The following is a description of a gene set: Mouse Gene Set: GOCC_LIPID_DROPLET An intracellular non-membrane-bounded organelle comprising a matrix of coalesced lipids surrounded by a phospholipid monolayer. May include associated proteins. species: Mus musculus, and this is the list of marker genes: Or6c6b, Ckap4, Adig, Pnpla7, Irak1, Atg2b, Ces1h, Plin1, Sigmar1, Rab40c, Pnpla5, Hsd3b7, Ces1d, Ces1b (NCBI Gene Id 382044), BC031181, Pla2g4c, Cldn11, Gapdhrt2, Vcp, Set, Sccpdh, Rap1b, Akap1, Ces1f, Alox15, Ehd1, Fig4, Spast, Gbf1, Tmt1a2, Cav1, Cyb5r3 (cytochrome b5 reductase 3), Gimap7, Plin3, Gapdhrt, Chka, Or6c6c, Ces1a, Ldah, Zw10, Zfyve1 (zinc finger, FYVE domain containing 1), Faf2, Osbpl2, Aqp7, Cidea, Smpd1, Vps13c, Irgc, Dhrs3, Rab40b, Aifm2, Hsd17b13, Mgll, Abhd5, Plin2, Rab5c, Atg2a, Hilpda, Rbp1, Ces1e, Pnpla2, Vps13a, Irgm1, Lipe, Katna1, Sdr16c5, Hsd17b11, Pnpla3, Rab7, Lpcat2, Anxa2, Acsl4, Ces1c, Cav2, Repin1, Rdh10, Plin4, Sdr16c6, Stard13 (StAR related lipid transfer domain containing 13), Rab18, Tmt1a3, Rsad2, Apob, Prpf19 (NCBI Gene Id 28000, pre-mRNA processing factor 19), Tmem135, Bscl2, Cideb, Or6c6, Tmt1b, Ces1g, Cidec, Gapdh, Tsc1, Ctdnep1, Aup1, Ldaf1, Lmln, Plin5, Lss, Rnf213, Tmt1a, Eda, Pitpnm1, Pisd, Aldh3b2, Bcap31, Ube2g2, Nsdhl, Igtp, ENSMUSG00000144291, Acsl3, Traf6, Clstn3, Lpcat1, Pnpla1, Hspa4, Abhd4, Spart, Gapdh-ps15, Dgat2